The following is a description of a gene set: species: Mus musculus An intracellular signaling cassette in which a small monomeric GTPase of the ARF subfamily relays a signal. Mouse Gene Set: GOBP_ARF_PROTEIN_SIGNAL_TRANSDUCTION, and this is the list of marker genes: Mapre2, Arfgef1, Git1, Iqsec2, Gbf1, Arfgef3, Grin2b, Psd, Psd4, Iqsec3, Iqsec1, Psd3, Arfgef2, Cyth1 (NCBI Gene Id 19157), Cyth2, Map4k4, Fbxo8, Git2, Grin2a, Cyth4, Cyth3, Arfgap1, Psd2